The following is a description of a gene set: species: Homo sapiens Gene up-regulated by CD40 signaling in Ramos cells (EBV negative Burkitt lymphoma). Human Gene Set: BASSO_CD40_SIGNALING_UP from publication Basso K, Klein U, Niu H, Stolovitzky GA, Tu Y, Califano A, Cattoretti G, Dalla-Favera R (PMID 15331443) Substantial evidence indicates that signaling through the CD40 receptor (CD40) is required for germinal center (GC) and memory B-cell formation. However, it is not fully understood at which stages of B-cell development the CD40 pathway is activated in vivo. To address this question, we induced CD40 signaling in human transformed GC B cells in vitro and identified a CD40 gene expression signature by DNA microarray analysis. This signature was then investigated in the gene expression profiles of normal B cells and found in pre- and post-GC B cells (naive and memory) but, surprisingly, not in GC B cells. This finding was validated in lymphoid tissues by showing that the nuclear factor-kappaB (NF-kappaB) transcription factors, which translocate to the nucleus upon CD40 stimulation, are retained in the cytoplasm in most GC B cells, indicating the absence of CD40 signaling. Nevertheless, a subset of centrocytes and B cells in the subepithelium showed nuclear staining of multiple NF-kappaB subunits, suggesting that a fraction of naive and memory B cells may be subject to CD40 signaling or to other signals that activate NF-kappaB. Together, these results show that GC expansion occurs in the absence of CD40 signaling, which may act only in the initial and final stages of the GC reaction., and this is the list of marker genes: CD83, CCL3, SYNGR2 (synaptogyrin 2), NCKAP1L, DTX2, BCL2A1, TMSB4X, ARHGEF2, RNF115, TNFAIP2, LYN, TNFSF9, IFI30, PHACTR1, CCR7, LRRC32, SNN, STK10, SH2B3, NFKB2, CD74, HSP90B1, LAPTM5 (lysosomal protein transmembrane 5), ICAM1, TNF, RAC2, STAT5A, HLA-F, LHFPL2, HLA-DQA1, IRF4, ZFP36L1, CD44, NEFM, CD40, UNC119, MTMR4, RXRA, PTP4A3, CCL4, TCFL5, IRF9, DDIT4, MAP3K8, HLA-DRB4 (major histocompatibility complex, class II, DR beta 4), IRF5, NCF2, JUNB, HLA-DPB1, TRIP10, VOPP1, BATF, PTK2B, LITAF, IGHG1, TNFAIP3, HTR3A, TNFAIP8, HLA-DQB1, PTPRE, TRAF1, CAPG, CHD1, MAPKAPK2, CD58, EHD1, GPR183, LTA, GADD45B (NCBI Gene Id 4616), HLA-DRB1, LGALS1, ELL2, ADAM8, RAB27A, FCMR, PLEK, BCL2, KCNN4, SRGN, NFKBIE, IER3, HLA-DMA, NFKBIA, ICOSLG, PLXNC1 (NCBI Gene Id 121370), CXCR5 (C-X-C motif chemokine receptor 5), DUSP2, RGS1, ELOA, TAP1, MEF2C (myocyte enhancer factor 2C), MYB, SIK1, CR2, CCL22, SLAMF1, TMC6, CFLAR, KRT7, PIK3CD, IL1B, STAT1, ARID5B